The following is a description of a gene set: Genes predicted to be targets of miRBase v22 microRNA mmu_miR_7045_3p in miRDB v6.0 with MirTarget v4 prediction scores > 80 (high confidence targets). from publication Chen Y, Wang X (PMID 31504780) Mouse Gene Set: MIR_7045_3P studied in species Mus musculus, and this is the list of marker genes: Zmym4, Gabbr2, Fgfr1, Hyal2, Ncam1, Epm2aip1, Htr3a, Setd5, Grik5, Gpnmb, Shc4, Larp1, Prss23, Trarg1, Taf8, Syne3, Map3k10, Sema4c, Gcn1, P2rx3, Asb7, Ddr1, Senp6, Cdk5r2, Sema6d, Gsx2, Wnk2, Zswim8, Slc13a3, Ets1, Chst11, Capn5, Ccl4, Fras1, Prph2, Pnma8a (PNMA family member 8A), Maml2, B3gnt6, Ypel3 (yippee like 3), Nf1, Nfix, Nufip2, Cacng2, Fnbp4, Spop, Taok3, Vps33b, Slc25a27, Calcrl, Mex3a, Trim24, Tbc1d16, Slc17a8, Aoah, Pced1a, S1pr1, Kif5c, Soat1, Scn2b, Slc47a1, Slfn5, Dyrk1b (NCBI Gene Id 13549), Brinp1, Col9a2, Lpgat1, Igf2r, Lrrc4, Irx1, Mtm1, Mgat4c, Tnrc6b, Dvl2, Lasp1, Dio3, Agap1, Zfp772, Egr3, Fbxl17, Ctsd (cathepsin D), Kmt2d, Zfp810, Etnk1